The following is a description of a gene set: electronically inferred by orthology from the curated human pathway This event has been computationally inferred from an event that has been demonstrated in another species.<p>The inference is based on the homology mapping from PANTHER. Briefly, reactions for which all involved PhysicalEntities (in input, output and catalyst) have a mapped orthologue/paralogue (for complexes at least 75% of components must have a mapping) are inferred to the other species. part of: Antimicrobial mechanism of IFN-stimulated genes Reactome Pathway: ISG15 antiviral mechanism species: Mus musculus, and this is the list of marker genes: Arih1, Eif4a1 (NCBI Gene Id 13681), Ube2e1, Ube2n, Uba7, Irf3, Rigi, Becn1, Eif4e3, Flnb, Eif4a2, Ppm1b, Mapk3